Given this list of marker genes ACVR2A, FSHB, FSHR, BAX, BCL2L2, FGF9, here is a description of the gene set: species: Homo sapiens Human Gene Set: GOBP_SERTOLI_CELL_PROLIFERATION The multiplication or reproduction of Sertoli cells, resulting in the expansion of the Sertoli cell population. A Sertoli cell is a supporting cell projecting inward from the basement membrane of seminiferous tubules.